Given this list of marker genes MLXIP, ZC3H4, ZBTB24, SPATA6, GMEB2, HELZ, RSPO1, KMT2B, TTC5, CWC25, ARID3B (AT-rich interaction domain 3B), TLR6 (toll like receptor 6), CHODL, RAB6B, BACH1, CNGA1, KDM4B, UCP2, HELZ2, FYB1, ESRP2, NKAPL, KHSRP, SLC20A1, IL1RAP, MYF5, KLHL12, PDE7A, PRAMEF8, ZFP69, EFCAB9 (NCBI Gene Id 651812), NCOR2, TOR3A, PRSS58, TMEM86B, FURIN, PPM1K, TRAK1, NUDCD3 (NCBI Gene Id 23386), MECP2, NLK, SF1 (NCBI Gene Id 7536), INPP5D, PML, HARS2, MIR488, BTD, RAB40C, DEFB4A, GRIPAP1, MDH1B, FFAR4 (free fatty acid receptor 4), SLC35E1 (solute carrier family 35 member E1), HMBOX1, SLC23A2, BAZ2A, CD2, HSPBAP1, L3MBTL3, BRAP, DHX16, PIK3R4 (phosphoinositide-3-kinase regulatory subunit 4), ERCC4, DDX23, KLHL42, FBRS, FOXN3, CCDC93, DDR1, TOMM34, DOP1B, FBXL4, DNTTIP1, EFCAB10, WIZ (WIZ zinc finger), LRRC7, CYLC1, NFRKB, GRAMD2A, TBXAS1, PYGM, PTGR3, PHF20, TAFA1, KIR3DL1, CRIM1, NEPRO, RBM43 (NCBI Gene Id 389054), FAM169BP (NCBI Gene Id 283777), ANKFY1, BBS9, FAM114A2, EHMT1, ZFP57, KIF2B, LRRC19, UBE2B, RBSN, R3HDM2, WDR33, NDOR1, MAP4K3, FGL1, SMAD7, CTNS, FUT11 (NCBI Gene Id 170384), VPS11, RHOBTB2, KCTD1, KBTBD3, VPS4B, PTPRE, B4GALT1, DNAJB9, SNED1, MIR202, TMCC1, STAU1, GPR65, SIKE1, GGCT, ADAT1, TXNL4B, ABLIM3, ESYT2, PRKCE, BICRAL, MCM3AP, SOD3 (NCBI Gene Id 6649), SPRR3, USP6NL, IQCA1, AFG3L1P, ZCCHC2, here is a description of the gene set: studied in species Homo sapiens from publication Dabrowska A, Kim N, Aldovini A (PMID 19050264) Human Gene Set: GSE12963_ENV_NEF_VS_ENV_NEF_AND_VPR_DEFICIENT_HIV1_INF_CD4_TCELL_UP The high mutation rate of HIV is linked to the generation of viruses expressing proteins with altered function whose impact on disease progression is unknown. We investigated the effects of HIV-1 viruses lacking Env, Vpr and Nef on CD4+ T cell gene expression using high-density DNA microarray analysis and functional assays. Genes up-regulated in CD4 T cells infected with Env/Nef deficient HIV-1 viruses versus those infected with HIV-1 viruses lacking Env, Nef and Vpr.